Given this list of marker genes BIRC2, CTSK, PCSK7, PABPC4, GRK3, SLC4A7, GLRA2, HS3ST1, DMXL2, CASP1, H2BC8, DDX10, PICALM, CSPG5, UBE4A, ATM, FUT8, AHR, LPCAT1, GSN, SIK3, PPP2R1B, CNR1, here is a description of the gene set: from publication Haslinger C, Schweifer N, Stilgenbauer S, Döhner H, Lichter P, Kraut N, Stratowa C, Abseher R (PMID 15459216) Human Gene Set: HASLINGER_B_CLL_WITH_11Q23_DELETION PURPOSE: Genomic aberrations and mutational status of the immunoglobulin variable heavy chain (VH) gene have been shown to be among the most important predictors for outcome in patients with B-cell chronic lymphocytic leukemia (B-CLL). In this study, we report on differential gene expression patterns that are characteristic for genetically defined B-CLL subtypes. MATERIALS AND METHODS: One hundred genetically well-characterized B-CLL samples, together with 11 healthy control samples, were analyzed using oligonucleotide arrays, which test for the expression of some 12,000 human genes. RESULTS: Aiming at microarray-based subclassification, class predictors were constructed using sets of differentially expressed genes, which yielded in zero or low misclassification rates. Furthermore, a significant number of the differentially expressed genes clustered in chromosomal regions affected by the respective genomic losses/gains. Deletions affecting chromosome bands 11q22-q23 and 17p13 led to a reduced expression of the corresponding genes, such as ATM and p53, while trisomy 12 resulted in the upregulation of genes mapping to chromosome arm 12q. Using an unsupervised analysis algorithm, expression profiling allowed partitioning into predominantly VH-mutated versus unmutated patient groups; however, association of the expression profile with the VH mutational status could only be detected in male patients. CONCLUSION: The finding that the most significantly differentially expressed genes are located in the corresponding aberrant chromosomal regions indicates that a gene dosage effect may exert a pathogenic role in B-CLL. The significant difference in the partitioning of male and female B-CLL samples suggests that the genomic signature for the VH mutational status might be sex-related. studied in species Homo sapiens Genes changed in the B cell chronic lymphocytic leukemia (B-CLL) with deletions in the 11q23 region.